The following is a description of a gene set: species: Homo sapiens Human Gene Set: GSE27786_CD4_TCELL_VS_NEUTROPHIL_DN Genes down-regulated in comparison of CD4 T cells versus neutrophils. from publication Konuma T, Nakamura S, Miyagi S, Negishi M, Chiba T, Oguro H, Yuan J, Mochizuki-Kashio M, Ichikawa H, Miyoshi H, Vidal M, Iwama A (PMID 21540074) Each fraction of mouse hematopoietic cells was purified by cell sorting from bone marrow of 8-week-old C57BL/6 mice, and its gene expression was analyzed., and this is the list of marker genes: VTA1, STAP2 (signal transducing adaptor family member 2), LRRC72, XBP1, ELOVL1, SH2D6, PPOX, UBE2F, IRS2, HSD17B7, VN1R5, WEE1, KLHL12, TMC4, MDM2, RNF167, CFAP119, PAG1, RPS6KA5, GINM1, IQSEC1, TNFRSF1A, GDE1, CDK2AP2, PSMB11, CDKL4, HIPK2, KRT80, RGN, CCNF, INPP5K, CCDC126, TFCP2L1, MVB12B, PCP4, CEP128, MSN, GPC1, BCO1, ZFP36, HOXB5, TINF2, AGR2, PTBP3, GUCY2D, TRAK2, AMOTL2, FAM114A1, RANBP9, RAB7A, CALCB, CASQ1, STARD5 (StAR related lipid transfer domain containing 5), S100G, NBEAL2, STRN3, AMDHD2, IL36A, EPN3, CREB3L1, PPP1R37, FGA, ARHGAP23, CLU, TCIM, MBD2, CREG2, SMIM14, CACNA1F, MAP3K3, ACTR10 (actin related protein 10), SENP2, UGDH, RALBP1, GAPDHS (NCBI Gene Id 26330), CBLN2, STK11, HOXD9, ACSL6, TIMP2, FNDC8, PPP1R3C, SMIM7, EVC2, MFSD4B (major facilitator superfamily domain containing 4B), HPN, RAD54B, ROCK2, PPP2CB, SASS6, RECK, TUSC1, SLC25A11, DHRS3, MAP1LC3B, FUT2, CRYZL1, PHF10, SRPX2, DYRK1A, TBL1XR1, GRIPAP1, USP47, APOH, CRK, DYNLL1, RIMBP2, SS18L2 (SS18 like 2), TBC1D24, TRAPPC14, PGGHG, ADAMTSL3, TSTD2, SLC1A7, SLC38A4, H2AX, NINJ1, AGTPBP1, ACVR1B, GUCY2C, SPARCL1, CH25H, JPH4, AQP9, LRRC74A, CAPZA1, KCTD10, SLC5A12, CIR1, ZNF217 (NCBI Gene Id 7764), GAS2L1, SMARCC2, PLG, SIGLEC10, P2RX1, NNT, SGO1, NDUFA1, BABAM2, NCK1, ENPP2, PADI3, SOS2, ARID3B, STAT3, PCOLCE, PPP2R5A, ZNF518A, CTBS, SLC2A12, SELP, RBM38 (NCBI Gene Id 55544), TASL, FBXL19, ENO1, ARMC3, SLC35C2, VILL, BAZ1A, TRAPPC6B, COX8A, BRK1, DEPTOR, ASB6, FZD3, RNF19B, PBXIP1, MOV10, LAMTOR1, LRRC4B, SLC12A6, ATG16L2, RIN3, ARMC7, C10orf90, OSM, PLA2G12B, STK17B, RHAG, MYO1C, PPP1R18, CHRM3, HIP1, PNPLA7, PRKG1, RFLNA, ARL6IP6, LARGE1, MLKL, PTGDR, TMEM165, MFSD9, ARHGAP24, CYP26A1, PLEKHH1, BDH2, BCL10, KNDC1, TMEM131 (NCBI Gene Id 55369), NCAPG2